The following is a description of a gene set: Human Gene Set: MIR139_3P Genes predicted to be targets of miRBase v22 microRNA hsa-miR-139-3p in miRDB v6.0 with MirTarget v4 prediction scores > 80 (high confidence targets). studied in species Homo sapiens from publication Chen Y, Wang X (PMID 31504780), and this is the list of marker genes: FN3K (fructosamine 3 kinase), ELK1, ADGRA1, LMO2, ANXA2R, CTU1, RPL22, UBE2G1, PLD5, CCDC71L, NOX4, PCLAF, MIER2, C1QL4, PLCH1, RAB8B